The following is a description of a gene set: NS1 Mediated Effects on Host Pathways Human Gene Set: REACTOME_NS1_MEDIATED_EFFECTS_ON_HOST_PATHWAYS species: Homo sapiens, and this is the list of marker genes: NUP214, NUP85, KPNA4, NUP50, POM121, NUP188, SEC13, NUP42, SEH1L, NUP98, NUP35, NUP160, KPNA2, NUP133, NUP54, NDC1, NUP153, KPNA3, AAAS, NUP93, NUP62, TPR, NUP155, KPNB1, RANBP2, KPNA5, CPSF4, POM121C, NUP205, KPNA7, PABPN1, KPNA1, NUP107, NUP210, RAE1, NUP37, EIF2AK2, NUP43, ISG15, NUP88, NUP58